Given this list of marker genes Hnrnpk, Bax, Dlx1, H2aj (H2J.A histone), Tra2b, Rnf7, Kcna1, Atp2b4, Fgf8, Csnk2a1, Zeb2, Usp9x, Pax6, Aspm, H2ax, Crk, Rhoa, Zbtb18, Th, Bbs1, Rara, Sox2, Large1, Plxna3, Pten, Nkx2-1, Pomt2, Btbd3, Dmrta2, Bcan, Atic, Mboat7, Neurod6, Kdm6b, Nars1, Dicer1, Prox1 (prospero homeobox 1), Pou3f3, Kcnq2, Srf, Nde1, Fut10, Btg2, Pex5, Hif1a, Rtn4, Casp3, Flna, Dab2ip, Rac1, Arx (NCBI Gene Id 11878), Srgap2, Eif2b5, Egfr, Cul5, Tsc1, Mfsd2a, Slc2a1, Anxa3, Cdk5r2, Sct, Fat4, Npy, Ogdh, Wdr47, Cdk5r1, Neurod1, Nf1, Zmiz1, Trp73, Dmd (NCBI Gene Id 93863), Cdh2, Afdn, Gart, Socs7 (suppressor of cytokine signaling 7), Robo1, Pax5, Lmx1a (LIM homeobox transcription factor 1 alpha), Scn2a, Tbr1, Srd5a2, Nefl, Nf2, Kcna2, Smo, Syne2, Fxr2, Fgf13, Ulk4, Nr2e1, Drd1, Mme, Xrn2, Fezf2, Nr2f1, Atat1, Cep120, Tmem108, Crkl, Dixdc1, Ncoa1, Trappc9, Gria1, Dab1, Atg16l1 (autophagy related 16 like 1), Uba6, Gli3, Ntrk2, Wdr62, Lhx6, Zic1, Bnip3 (NCBI Gene Id 12176), Fbxo41, Lhx5, Tubb2b, Ccdc85c, Mdga1, Dcx, Atoh1, Reln, Kif26a, Fbxo45, Lhx2, Bbs2, Tacc2, Phactr1, Col3a1, Xrcc1, Lef1, Adgrg1, Filip1, Fez1, Psen1, Tacc1, Kirrel3, Fktn, Lamb1, Tsku, Pex13, Kif3a, Ctnnb1, Nr4a3, Htr5a, Akirin2, Uqcrq, Celf1, Emx2, Dclk2, Sun2, Bhlhe22, Fgfr1, Mecp2, P2ry12, Mas1, Mgarp, Hdac1 (NCBI Gene Id 630524), Fos, Lrp6, Ndel1, Nfix, Igf2bp1, Plcb1, Pomgnt1, Pianp, Eomes, Mkks, Atg7, Gsk3b, Htr6, Alk, Mcph1, Lrp8, Nsun5, Efhc1, Ptprs, Cdon, Emx1, Tacc3, Sun1, Bbs4, Bmerb1, Hdac2, Ywhae, Bloc1s6, Fxr1, Lypd6, Mdk, Slit2, Atp1a3, Ezh2, Sema6b, Vps13b, Slc32a1, Abcc1, Dlx2, Csf1r (NCBI Gene Id 12978), Zic3 (zinc finger protein of the cerebellum 3), Id4, Ppp1r9b, Kdm1a, Epha5, Foxg1, Pafah1b1, Ccdc141, Tuba1a, Pou3f2, Slc38a2, Kif14, Pals1, Tfap2c, Tubb2a, Ascl1, Ccdc39, Cdk5, Wnt3a, Disc1, Grin1 (glutamate receptor, ionotropic, NMDA1 (zeta 1)), here is a description of the gene set: species: Mus musculus Mouse Gene Set: GOBP_PALLIUM_DEVELOPMENT The process whose specific outcome is the progression of the pallium over time, from its formation to the mature structure. The pallium is the roof region of the telencephalon.